Given this list of marker genes F12, SFRP1, PLEKHH3, MDK, NOL3, PLAUR, BRSK1, CISH, PRDM13, PPP1R14A, CACNA1E (calcium voltage-gated channel subunit alpha1 E), MAGEC1, OTUD7A, TRIM46, PCK2, PLTP, IMPDH1, SNAPC2, SLC39A4, ICAM3, MAOA, APOE, IFITM2, GRIN1, STX6, OSCAR (osteoclast associated Ig-like receptor), TNNT1, CENPBD1P, SRD5A3, UCHL1, FOXB1, PNPLA6, SLC16A5, GALC, OR5B12, POMK, TXNIP, BCAS3, HEYL, SERPINH1, PACSIN3, CYBA, TNNI3, NLE1, IL4R, ISYNA1, FOXS1, SLC27A5, TMEM121, STK16, COA7, FXYD5, GTPBP3, SLC29A1, CFD, LHPP, PITPNC1, BARX1, FZD9, TRPM4, MAGEE1, RCN3, GPR78, GDF15, FOXF2, KISS1R, PARD6G, INKA1, UTS2R, COL6A1, KLF2, NOL6, PAGR1, S100A3, FOXD2, LIMD2, VCX3A, POLR3E (RNA polymerase III subunit E), TWIST2 (twist family bHLH transcription factor 2), TSPY1, SAC3D1, SHC1, KMT5C, ALDOC, SOX4, ASB2, TMEM45A, FSTL3, SH3D21, CDH2 (NCBI Gene Id 1000), RPP25, RPP25L, GRWD1, HLA-DRB3, PYCR1, CCL19, PTPRF, MTA1, MRPL2, MAGEA3, PHLDA2, HTR1A, ADRA2C, STEAP3, UBIAD1, SERPINB1, ISG15, CCDC85B, VASP, DDAH2, KRT18, CPT1C, ANGPTL4, SGSH, CEP250, TIMP3, TRIM16, H2AC8, MAGEA6, VAV3 (NCBI Gene Id 10451), SLC1A5, CMIP, BEGAIN, NR1H3, FZD5, USE1, IL24, TRAC, ADA, SLCO4A1, PCDH11Y, EMILIN1, TP53I3, SMARCD2, ARRB1, BATF3, VCX, SLC5A6, ICAM1, SPHK1, H1-10, VCP, FHOD1, FZR1, SSTR2, ZNF329, SPON2, CXCR3, DEF6, FBLN1, VCX2, MEPCE, NMB, TRAF4, CDC34 (NCBI Gene Id 997), KLK6, CCKBR, JUN, INF2, TSC22D4, BCL3, EFNA1, LRRC14, RNF32-DT, TERT, H2BC3, CD19 (CD19 molecule), ASPHD1, MAPK8IP2, ARAP3, SLC15A3, ECHDC3, PCDHB2, HIF1A, MAGEA1, ERF, SCLY (NCBI Gene Id 51540), GFOD1, SH3GL3, SH3BP1, TAGLN2, TYMP, SIGLEC15, KCNG1, SLC37A2, TMEM42 (transmembrane protein 42), KYNU, HOXB9 (NCBI Gene Id 3219), MYBPC2, SYNGR4, TAOK2, RPS6KA1 (NCBI Gene Id 6195), ERBB2, KCNA5, ZNF629, TSPY2, BLCAP, CHMP1A, GSE1, DHRS2, ZSCAN10, VSIG10L, PGAM2, here is a description of the gene set: from publication Hamaï A, Richon C, Meslin F, Faure F, Kauffmann A, Lecluse Y, Jalil A, Larue L, Avril MF, Chouaib S, Mehrpour M (PMID 16983347) In order to define genetic determinants of primary and metastatic melanoma cell susceptibility to tumor necrosis factor-related apoptosis-inducing ligand (TRAIL), we have applied oligonucleotide microarrays to TRAIL-sensitive primary T1 cells and TRAIL-resistant metastatic G1 cells treated or not with TRAIL. T1 and G1 cells are isogenic melanoma cell subclones. We examined 22 000 spots, 4.2% of which displayed differential expression in G1 and T1 cells. Cell susceptibility to TRAIL-mediated apoptosis was found to be correlated with gene expression signatures in this model. Some of the differentially expressed genes were identified as involved in ATP-binding and signaling pathways, based on previously published data. Further analysis provided evidences that c-kit was overexpressed in G1 cells while it was absent in T1 cells. The c-kit inhibitor, imatinib, did not restore TRAIL sensitivity, excluding a role for c-kit in TRAIL resistance in G1 cells. Surprisingly, imatinib inhibited cell proliferation and TRAIL-mediated apoptosis in melanoma cells. We investigated the possible involvement of several molecules, including c-ABL, platelet-derived growth factor receptor (PDGFR), cellular FADD-like interleukin-1 alpha-converting enzyme-like inhibitory protein (c-FLIP)(L/S), Fas-associated DD kinase, p53, p21(WAF1), proteins of B-cell leukemia/lymphoma 2 (Bcl-2) family and cytochrome c. Imatinib did not modulate the expression or activation of its own targets, such as c-ABL, PDGFRalpha and PDGFRbeta, but it did affect the expression of c-FLIP(L), BCL2-associated X protein (Bax) and Bcl-2. Moreover, c-FLIP(L) knockdown sensitized T1 cells to TRAIL-mediated apoptosis, with a sensitivity similar to that of cells previously treated with imatinib. More notably, we found that the resistance to TRAIL in G1 cells was correlated with constitutive c-FLIP(L) recruitment to the DISC and the inhibition of caspase 8, 3 and 9 processing. Moreover, c-FLIP(L) knockdown partly restored TRAIL sensitivity in G1 cells, indicating that the expression level of c-FLIP(L) and its interaction with TRAIL receptor2 play a crucial role in determining TRAIL resistance in metastatic melanoma cells. Our results also show that imatinib enhances TRAIL-induced cell death independently of BH3-interacting domain death agonist translocation, in a process involving the Bax:Bcl-X(L) ratio, Bax:Bcl-X(L)/Bcl-2 translocation, cytochrome c release and caspase activation. Our data indicate that imatinib sensitizes T1 cells by directly downregulating c-FLIP(L), with the use of an alternative pathway for antitumor activity, because PDGFRalpha is not activated in T1 cells and these cells do not express c-kit, c-ABL or PDGFRbeta. Caspase cascade activation and mitochondria also play a key role in the imatinib-mediated sensitization of melanoma cells to the proapoptotic action of TRAIL. Human Gene Set: HAMAI_APOPTOSIS_VIA_TRAIL_DN Genes down-regulated in T1 cells (primary melanoma, sensitive to TRAIL) compared to G1 cells (metastatic melanoma, resistant to TRAIL). studied in species Homo sapiens